The following is a description of a gene set: species: Homo sapiens Human Gene Set: LI_PBMC_MENACTRA_AGE_18_45YO_ANTI_POLYSACCHARIDE_ANTIBODY_CORRELATION_PROFILE_3DY_UP Many vaccines induce protective immunity via antibodies. Systems biology approaches have been used to determine signatures that can be used to predict vaccine-induced immunity in humans, but whether there is a 'universal signature' that can be used to predict antibody responses to any vaccine is unknown. Here we did systems analyses of immune responses to the polysaccharide and conjugate vaccines against meningococcus in healthy adults, in the broader context of published studies of vaccines against yellow fever virus and influenza virus. To achieve this, we did a large-scale network integration of publicly available human blood transcriptomes and systems-scale databases in specific biological contexts and deduced a set of transcription modules in blood. Those modules revealed distinct transcriptional signatures of antibody responses to different classes of vaccines, which provided key insights into primary viral, protein recall and anti-polysaccharide responses. Our results elucidate the early transcriptional programs that orchestrate vaccine immunity in humans and demonstrate the power of integrative network modeling. Genes up-regulated in peripheral blood mononuclear cell 3d vs 0d in adults (18-45) (anti-polysaccharide antibody-correlation profile) after exposure to Menactra, time point 3D from publication Li S, Rouphael N, Duraisingham S, Romero-Steiner S, Presnell S, Davis C, Schmidt DS, Johnson SE, Milton A, Rajam G, Kasturi S, Carlone GM, Quinn C, Chaussabel D, Palucka AK, Mulligan MJ, Ahmed R, Stephens DS, Nakaya HI, Pulendran B (PMID 24336226), and this is the list of marker genes: TNF, IFNA16, IL6, IFNA2, LHCGR, CCL20, C1R, GPX1, C1QB, C3AR1, PTX3, FGF5, AIF1, FCER1G, TLR4, TBC1D8 (TBC1 domain family member 8), APOBR, CXCL8, C2, IFNA21, CFI, CARD9, SERPING1, ST14, IL1B, C1QA, CCRL2, TYROBP, C3, C5AR1, IFNA4, CFD